Given this list of marker genes Kcnd2, Slc4a10, Prepl, Tspan17, Slc13a3, Thy1, Rian, Calb1, Mapre3, Ndrg4, Kcnk1, Rab4a, Chchd10, Kif1a, Vsnl1, Pcp2, Ntm (neurotrimin), Slc32a1, Rab3a, Cbln1, Nefh, Mapre2, Ppp1r3c, Masp1, Gucy1a1, Tspan2 (NCBI Gene Id 99873), Pcsk1n (NCBI Gene Id 30052), Atp2b2, Hk1, Slc1a6 (NCBI Gene Id 20513), Itpka (NCBI Gene Id 228550), Sema3e, Ablim1, Asph, AI593442, Atp1b1, Cacna1g, Prkcg, Dclk1, Fnbp1, Itpr1, Gad1, Rcan2, Lynx1, C1qtnf4 (C1q and tumor necrosis factor related protein 4), Pak1, Car8, Ncam1, Slc8a1, Syt1, Atp2a2, Grm3, Vamp2, Aldh1l1, Zic3, Penk, Clstn2, Lrp8, Cend1, Gria1, Pdxk, Napb, Trpc3, Spock2, Rora, Mir124-2hg, Ckmt1, Map4 (NCBI Gene Id 235620), Cnih2, Cnp, Dynlt3, Camk2d, Csdc2, Skor1, Tmem50b, Ptprr, Nrxn3, Nrsn1, Sez6l2, Meg3, Cds1, Elmod1, Gja1, Ptgds, Nrip3, Fam241b (NCBI Gene Id 69894), Hmgcs1, Kif5a, here is a description of the gene set: from publication Lee Y, Kawagoe R, Sasai K, Li Y, Russell HR, Curran T, McKinnon PJ (PMID 17452975) The Sonic Hedgehog (SHH) signaling pathway is indispensable for development, and functions to activate a transcriptional program modulated by the GLI transcription factors. Here, we report that loss of a regulator of the SHH pathway, Suppressor of Fused (Sufu), resulted in early embryonic lethality in the mouse similar to inactivation of another SHH regulator, Patched1 (Ptch1). In contrast to Ptch1+/- mice, Sufu+/- mice were not tumor prone. However, in conjunction with p53 loss, Sufu+/- animals developed tumors including medulloblastoma and rhabdomyosarcoma. Tumors present in Sufu+/-p53-/- animals resulted from Sufu loss of heterozygosity. Sufu+/-p53-/- medulloblastomas also expressed a signature gene expression profile typical of aberrant SHH signaling, including upregulation of N-myc, Sfrp1, Ptch2 and cyclin D1. Finally, the Smoothened inhibitor, hedgehog antagonist, did not block growth of tumors arising from Sufu inactivation. These data demonstrate that Sufu is essential for development and functions as a tumor suppressor. Genes down-regulated in medulloblastoma tumors from animals with inactivating mutations of one copy of PTCH1 or SUFU in conjunction with TP53 loss. species: Mus musculus Mouse Gene Set: LEE_TARGETS_OF_PTCH1_AND_SUFU_DN